The following is a description of a gene set: from publication Chen Y, Wang X (PMID 31504780) Genes predicted to be targets of miRBase v22 microRNA mmu_miR_5125 in miRDB v6.0 with MirTarget v4 prediction scores > 80 (high confidence targets). Mouse Gene Set: MIR_5125 studied in species Mus musculus, and this is the list of marker genes: Snx12, Vezf1, Gsk3b, Usp49, Vipr1, Erlec1 (endoplasmic reticulum lectin 1), Dcun1d4, Syn3, Rab37, Tmem258, Crb2, Snx11, Cyyr1, Nectin2, Kat6a, Ccdc157, Katnb1, Colgalt1, Cyb561a3, Usp32, Celf2, Zfp609, Fignl2, Usp34, Ttpal, Calcr, Mau2, Gjb1, Ccdc71, Carns1 (carnosine synthase 1), Wwtr1, Tcte2, Fndc8, Mettl21e, Aak1, Cndp2, Arhgdia, Raver2, Ddx3x, Camk1d, Tmem163, Galnt10, Ptges3, Zfp869, Ankub1, Trp53i11, Dock3, Cbl, Mb21d2, Cacnb3, Cntf, Pla2g15, Rgs8, Nr4a2, Kcnip1, Crk, Tas1r3, Mecp2, Cybc1, Gpr157, Trabd2b, Ano6, Nsd1, Ptpn11, Zfc3h1, Aff1 (NCBI Gene Id 57071), Nsdhl, Ankrd52, Fgf13, Zbtb46, Krtap2-20, Hnrnpdl, Mapkap1, Esyt2, St8sia2, Syt9, Gabra2 (gamma-aminobutyric acid type A receptor subunit alpha 2), Phc1, Gspt1, Rbm39, Lingo4, Cntn2, Ccr9, Akap6, Wnt7a, Fem1a, Prkcb, Kcnb2, Rpl7l1, Fmod, Il13ra1, Zfand5, Tpbgl, Zbtb39, Bcl6 (NCBI Gene Id 12053), Afg1l, Polr3h, Aida, Hectd4, Slc25a36, Lysmd4, Cd164, Meis1